The following is a description of a gene set: An abnormal reduction in the ability to masticate (chew), i.e., in the ability to crush and ground food in preparation for swallowing. studied in species Homo sapiens Human Gene Set: HP_IMPAIRED_MASTICATION Impaired mastication, and this is the list of marker genes: MT-CO1, MAP3K20, OBSCN, CHRNA1, PYROXD1, WNT10A, HLA-B, NAA20, PAX9, MYL2, EDA, ALS2, SELENON, PPP2R5D, SLC39A14, LPIN1, PTPN22, TUBB3, MSX1, IDS, GNAI3, H4C5, TPM2, TGFA, AXIN2, IRF6, NECTIN1, ITGA7, ACTA1, KANSL1, P4HA2, GRIN1, ADNP, COLQ, TP63, LAMB2, HACD1, AHDC1, HLA-DRB1, FGFR1, WNT10B, NEUROG1, MTRFR, TPM3, LRP6, PYGM, SUMO1, MT-CO3, LAMA2 (laminin subunit alpha 2), HOXB1, ADSS1, FARS2, EDARADD